Given this list of marker genes PSMD8, UBA52, PSMD1, ABCC4, SEL1L, ABCB4, PSMA2, ERLEC1, ABCD3, PSMA6, PSMD6, PSMB1, PEX3 (NCBI Gene Id 8504), PSMC4, PEX19, KCNJ11, PSMC2, ABCC9, SEM1, PSMC1, PSMA3, ABCC6, PSMD11, PSMA1, ABCA12, ABCA2, DERL1, ABCB5, ABCB9, ABCA3, PSMD14, PSMA4, EIF2S3 (eukaryotic translation initiation factor 2 subunit gamma), PSMC3 (proteasome 26S subunit, ATPase 3), EIF2S2, PSMC5, CFTR, ABCC5, VCP, ABCB6, PSMB7, ABCD1 (ATP binding cassette subfamily D member 1), APOA1, PSMB4, ABCG5, PSMD3, DERL3, ABCG8, ABCC1, PSMD7, PSMB6, ABCA4, EIF2S1, ABCG1, ABCB8, RNF185, PSMB2, ABCB7, ABCC3, PSMC6, ABCA9 (NCBI Gene Id 10350), ABCG4, ABCA10, ABCC10, PSMA5, PSMA7, PSMB3, ERLIN1, ABCD2, PSMB5, ERLIN2 (NCBI Gene Id 140906), ABCA6, UBB, RPS27A, ABCB1, ABCB10, ABCC11, RNF5, ABCA7, DERL2, ABCA5, ADRM1, ABCF1, UBC, OS9, ABCC2, ABCA8, PSMD13, PSMD2, PSMD12, here is a description of the gene set: studied in species Homo sapiens ABC-family proteins mediated transport Human Gene Set: REACTOME_ABC_FAMILY_PROTEINS_MEDIATED_TRANSPORT